The following is a description of a gene set: from publication Dik WA, Pike-Overzet K, Weerkamp F, de Ridder D, de Haas EF, Baert MR, van der Spek P, Koster EE, Reinders MJ, van Dongen JJ, Langerak AW, Staal FJ (PMID 15928199) T cells develop from progenitors that migrate from the bone marrow into the thymus. Thymocytes are subdivided roughly as being double negative (DN), double positive (DP), or single positive (SP), based on the expression of the CD4 and CD8 coreceptors. The DN stage is heterogeneous and can be subdivided into four distinct subsets in mice based on the expression of CD44 and CD25. In human, three distinct DN stages can be recognized: a CD34+CD38−CD1a− stage that represents the most immature thymic subset and the consecutive CD34+CD38+CD1a− and CD34+CD38+CD1a+ stages. Human DN thymocytes mature via an immature single positive (ISP CD4+) and a DP stage into CD4+ or CD8+ SP T cells that express functional T cell receptors (TCR) and that exit the thymus. In this study, gene expression was measured in each of these nine stages. Human Gene Set: GSE22601_DOUBLE_POSITIVE_VS_CD4_SINGLE_POSITIVE_THYMOCYTE_DN studied in species Homo sapiens Genes down-regulated in thymocytes: double positive versus CD4 single positive., and this is the list of marker genes: SEPTIN10, SRBD1, PCBP2, POC1A, SHMT2, SLC36A4, TRIM59, PTP4A3, RNF168, PNP, NSMCE1, COX6B2, PSIP1, TPGS2, ILVBL (NCBI Gene Id 95885), POLE3, UNC93B1, TIAM1, BATF3, PDS5B, GINS2, TRIM28, WDR62, RAB8B, DNM1L, PITRM1, H2AX, PRKRA, RFC4, SEPHS1, PTRH2, TMEM120A, NAGK, ARL6IP1, TPX2, NELFCD, ANP32E, KCTD2, LRRC75A, CKAP2L, KIF11, ARMCX3, TFB1M, MIF4GD, CDCA7L, CENPC, CBX5, TNFRSF8, CCNE1, CPNE2, KAT14, E2F8, CIP2A, TCOF1, CENPA, SMC4, RFWD3, WDR90, CCNE2, FAM162A, RPP30, DYNLL2, HIRIP3, GEMIN6, SLC25A24, LBP, RGS10, KIF2C, CLDND1, DECR1, SAPCD2, NRN1, IDE, MRPL51, CD52, RACGAP1, TXN, PAXIP1, TACC3, ATP5F1B, CIT, FABP5, NUP37, RCC2, STIP1, CD28, ATAD2 (NCBI Gene Id 84325), FRA10AC1, UBAC1, KIF4A, ZWILCH, MCM2, DHFR, GLOD4, NFYB, VDAC3, CNIH4, LRRCC1, NCF4, RRM1, MRS2, HAT1, GET4, MSH6, RNASEH2C, HAUS3, JDP2 (Jun dimerization protein 2), NDE1, TFDP1, CENPJ, NSL1, IPO9, DACH2, GLT8D1, SIRT5, RBL1, LNPK, HDGF, MPHOSPH9, ALKBH7, SMS, CD81, DCAF4 (DDB1 and CUL4 associated factor 4), CSRP1, TDP1, TUBA1B (NCBI Gene Id 88851), SDHAF3, EXO1, LGALS1, DCTPP1, ERI1, ITM2A, NAP1L1, NAA38, CLN6, KDM2B, POLR2E, CTNNA1, TUBE1, NEFH (neurofilament heavy chain), SNRPD2, PCNA, MAD1L1, RAD50, CYB561A3 (cytochrome b561 family member A3), NCAPD2, PAQR4, GTSE1, ESCO2, C11orf54, SUPT3H, CHCHD5, C18orf54, PENK, ECH1, INCENP, UCHL3, BRCA1, IFT74, SPDL1, CDC123, BRCC3, PRDX4, ANXA4, TAF6L, UCHL5, MALT1, POP4, MDM1, DHX29, MBD4, PGP, CENPS, SSRP1, RAD54L, NCAPH, CENPI, DARS2, AARSD1 (alanyl-tRNA synthetase domain containing 1), NCAPG, HJURP, NUP205, TMEM218, POLH, PRMT1, NDC1 (NCBI Gene Id 55706), EME1, ACTG1, LSM3, PDZD11, SAAL1, SLC66A3, CCDC18, CCDC77, DTNBP1, CENPL, CDKN1A, ST13, TUBG1, NPM1